Given this list of marker genes ELOVL2, ZNF765, PIP4K2A, SCRN1 (NCBI Gene Id 9805), FGF14, UCK2, ALS2, NADK, RFX3, SFTPA1, CHD6, MGAT2, GABARAPL2, LATS2, USP45, MTPN, YTHDF3, STAM, PPM1A, CREB1, INO80D, KPNA3, TENT4B, PAIP2 (NCBI Gene Id 51247), LRRC3, PTAR1, CDC42, ARMCX4, LCOR, VIP, RNGTT (NCBI Gene Id 8732), RB1CC1, PPP1R9A, ZNF397, SUPT20H, ACSS3, SLC25A32, GSKIP, RYR2, SAMD8, CELF5, CD58, NMNAT2, RBAK, HDAC9, MED28, BTBD7 (BTB domain containing 7), ACO2, RRAGC, ZNF641, CDC7, TENM2, KRR1, POU3F3, NUMB, RABGEF1 (RAB guanine nucleotide exchange factor 1), RNMT, MFN1, RALGPS2, SETD3, ZNF248, MEX3C, MTHFD2L, ELMOD1 (NCBI Gene Id 648653), AFF1, SV2B, PAK2, TRIB1, FAR1, PTGES3L, ATRX, STK38L, PRKACB, TOMM20L, FAM199X, WDR36, FBXL17, SEMA4F, ATL3 (NCBI Gene Id 283241), KCTD12, GNG2, TRIM33, NHSL3, KIF13A, LRRTM3, EIF4E, KPNA4, PPARGC1A, PLP1, SS18, JADE1, COX5A, CPSF2, SNAPC1, ZNF793, SEMA4C, SNX13, TMTC4, TFEC, SEL1L, SREK1, C8orf48, TMC7, SLC6A20, SYT4, SERTAD2, RCSD1, RNF103, PLCB1, CCDC47, TBL1XR1, PARD6G, TRHDE, L2HGDH, ACKR4, NHLRC3, RASGEF1B (RasGEF domain family member 1B), UBE2V2, ZNF322, HAPLN1, ALKBH5, CLK4, SEC22C, PNISR, SHCBP1, HOXB5, DLL1, ADRB2, LRRC3B, CLEC5A, GABRP, SPRED1, N4BP2L1, GCSAML, ZBTB44, FBLN5, GADL1, VMA21, CD96, DPP10, NFAT5, CP, RPS27L, OLFML2A, TDP1, XRN1, SNAPC3, RLF, MAP4K5, SLC30A5, SYT1, CETN1, TMEM41B, GUCY1A2, SOS2, GTF2H2, FOXN2, NETO1, ZNF709, STYK1, MAP3K1, CA8, MAPRE1, CAPZA2, ATP2C1, GXYLT1, RNPS1, ZBTB26, OTUD4, AKT2, ZBTB33, NUDT7, ARAP2, RHNO1, VEZT, CYP20A1, BRWD1, GPAM, CD47, DICER1, RPL22L1, IFIT5, TRIB2, GLUL, RPL34, ADAM10, EPN2, CASP7, ATP8A1, MIB1, LAMC2, RAD21, CTR9, SLC4A4, UBE2K, ETV1, ACTN4, LY6G6C, MYO1B, CYP2C18, LMTK2, EDEM1, CNOT6L, TMEM168, ARPC2, COL5A2, CRYBG3, CACNA1D, FEZ1, TMED4, SLC16A7, ZNF33A, MED1, GTPBP4, RC3H1 (NCBI Gene Id 149041), BRAT1, GDAP2, HAPSTR1, RLIM, PRKG2, RAPGEF2, SAR1B, MXI1, H2AZ2, ZEB2, BHLHE41 (NCBI Gene Id 79365), RERE, PGR, S1PR5, KATNBL1, PRDM1, ARHGAP35, RAB30, here is a description of the gene set: from publication Chen Y, Wang X (PMID 31504780) Genes predicted to be targets of miRBase v22 microRNA hsa-miR-888-5p in miRDB v6.0 with MirTarget v4 prediction scores > 80 (high confidence targets). species: Homo sapiens Human Gene Set: MIR888_5P